Given this list of marker genes TNFRSF4, TNFRSF11A, TNFRSF14, FAS, TNFRSF18, TNFRSF25 (TNF receptor superfamily member 25), TNFRSF1B, TNFRSF19, TNFRSF1A, EDA2R, here is a description of the gene set: studied in species Homo sapiens Combining with tumor necrosis factor, a proinflammatory cytokine produced by monocytes and macrophages, to initiate a change in cell function. Human Gene Set: GOMF_TUMOR_NECROSIS_FACTOR_RECEPTOR_ACTIVITY